The following is a description of a gene set: species: Homo sapiens The increase in size or mass of the heart. Human Gene Set: GOBP_HEART_GROWTH, and this is the list of marker genes: PARP2, FOXC1, SAV1, MIR590, TBX2, EDN1, MIR509-1, MIR208A, MYH6, MEIS1, YAP1, MIR23A, VGLL4, SKI, MIR222, YY1, PAK1, RXRB, MIR195, ERBB4, MAPK14, MIR1-1, WT1 (NCBI Gene Id 7490), ZFPM2, FES, MAPK11, KRAS, FOXP1, GSK3A, G6PD, CAV3, MIR873, FGF9, WNT2, KCNK2, FGF20, GATA6, AKAP6, FGFR1, TBX20, TENM4, CTDP1, TGFBR3, IGF1, MIR548C, BMP10, MIR19A, MESP1, MEF2C, ABL1, PRKG1, CDK1, PRKAR1A, RGS4, FGF2, RUNX1, ARID2, RBPJ, NKX2-5 (NK2 homeobox 5), S1PR1, RBP4 (retinol binding protein 4), CCNB1, NPPA, RGS2, ADRA1A, DUSP6, JARID2, TP73, BASP1, MIR199A1, SORBS2, PDLIM5, TGFBR1, ACACB, MIR24-1, MIR200B, PROX1, MIR204, SMAD1, DIPK2A (NCBI Gene Id 205428), GATA4, MYH10, TGFB2, TBX5, MIR199B, FGFR2, NOTCH1, NRG1, MIR17HG, ADPRHL1, MIR19B1, PI16, PPARA, HEG1, COL14A1, GLI1, MIR25, FOXC2, TOMM70, NOG, BMPR1A, NDRG4, PIM1, HEY2